Given this list of marker genes UBALD2, TCEAL7, TMEM126B, TLE4, GPR85, BMP4, C2CD5, MBNL1, POU3F4, EPC2 (NCBI Gene Id 96643), C1orf122, DENND1B, OTP, NPAS3, FRMD5, CNTN5, GOLGA2P5, ANGPT1, SLTM, TLE1, SMURF2, MRPS18B, TEX47, ZHX3, SOX4, BCL6, SNTG1, ROM1, BAIAP2, ATOH7 (NCBI Gene Id 54719), MEIS2, PELI2, ARMCX3, PHOX2B, H3-3B, TAL2, PPP1R10, KLF3-AS1, PTCHD4, SIPA1, EMP3, EPC1, ARID3B, SLC26A7, EPHB6, OR2H1, TNR, SP8, TGIF1, CHM, ZFHX3, HOXB8, TENT4B, NFIX, TLX3, BACH2, PCDHGB7, OLFM1, RHOBTB1, SNX6, DMD, NEO1, RAMP1 (NCBI Gene Id 10267), SREK1, PPP2R3A, SEM1, BHLHE22, PAK1IP1, CDKN2B, AQP9, SLC9A9, OCRL, RAX, DPF3, EML3, HOXB1, MTF1, C2orf66, DNAI4, NR2F2, NDP, GSX1, ATF7IP, SLITRK2, SLC10A2, DLL1, CUX1, TYRO3, PALS1, ZIC1 (NCBI Gene Id 7545), GOLGA6L2, HOXB5, KLHL5, FES, HOXD4, ATP6AP1, OGN, SYTL4, BMI1, ENSG00000291228, ZPLD1, SLC39A14, MEF2C, PLXNA2, LMO1, EBF2, PURA, COLCA1, SRMS, DSG1, GNAI1, SREBF2, ADGRL2, GOLGA6L9, SYNCRIP, MAML3, PPP2R2A, SLF2, IGSF21, CTNND2, FOXN3, CLEC4E, PDLIM5, MYH11, GSC, HRK, LPAR4, PPP1R21, TENM3-AS1, HESX1, STK39, SRSF8, DYRK1A, SF3B4, ADAMTSL2 (NCBI Gene Id 9719), ENTPD5, KCNA2, YRDC, PMEPA1, DPYD, FLI1, BARHL2, FGF6, CELF4, GDNF, CACHD1, SIAH3, SI, ELOA, SEMA6D, PRDM8, RNF212, SESN2, ZIC4, FOXO3, GOLT1A, KLF3, PLCD1, SLC20A1, C8A, CCND1, GOLGA6A, SMARCA2, EFEMP1, ARPP19 (cAMP regulated phosphoprotein 19), DCN, NONO, MED13, CNMD, CEP120, CTSK, DOCK1, MOS, OTX2, TENM1, PRDM1, BCL11A, EXPH5, STARD13, HAPLN1, SLC36A2, HSPB2, EPYC, NR4A2, RALGDS, SGIP1, LIX1, RASGRF1, CLEC18C, CASK, LMO3, ACACA, RNF14, NECAP1, SOBP, POLR3GL (RNA polymerase III subunit GL), CPLX2, FUT8, C14orf39, ZIC3, MIER1, PNOC, UBR5, SLC44A1, CLVS1, ELOVL6, RIMOC1, INPPL1, LEMD1, PITX2, ELAVL4, ANAPC15, SLC35G2, BEND4, IP6K2, OTX1, SLC24A4, RAB5C, CBFA2T2, HMGB2, KRTAP15-1, TCF12, GC, FEZF2 (FEZ family zinc finger 2), HNF1A, CDC42EP3, DNAJC10, ZNF827, NR2E1, SRSF7, TBCC, LOX, CSRNP3, CLDN14, HAUS4, CD274, PDZK1IP1, TPP1, CCDC120, PGM1 (phosphoglucomutase 1), NRP1, NSMCE3, BDNF, EGR2, PALS2, SLC10A4, XYLT2, PPP3CC, EFNB1, TNMD, POT1, SALL3, LIME1, RNF24, VSIG1, SAMD11, ARPP21, GDF7, here is a description of the gene set: Human Gene Set: IPF1_Q4 Genes having at least one occurrence of the motif GHNNTAATGACM in the regions spanning 4 kb centered on their transcription starting sites. This matches the IPF1 transcription factor binding site V$IPF1_Q4 (v7.4 TRANSFAC). species: Homo sapiens